Given this list of marker genes Gdnf (NCBI Gene Id 14573), Hes3, Plxna3, Sema3f (NCBI Gene Id 20350), Nav2, Phox2a, Adarb1, Ackr3, Nrp1, Nrp2, Sema3a, Hoxb1, Ascl1, Hoxa1, Tbx1, Plxna4, Egr2, Six1, Tfap2a, Hes1, Phox2b, Hoxb2, here is a description of the gene set: The process whose specific outcome is the progression of the parasympathetic nervous system over time, from its formation to the mature structure. The parasympathetic nervous system is one of the two divisions of the vertebrate autonomic nervous system. Parasympathetic nerves emerge cranially as pre ganglionic fibers from oculomotor, facial, glossopharyngeal and vagus and from the sacral region of the spinal cord. Most neurons are cholinergic and responses are mediated by muscarinic receptors. The parasympathetic system innervates, for example: salivary glands, thoracic and abdominal viscera, bladder and genitalia. species: Mus musculus Mouse Gene Set: GOBP_PARASYMPATHETIC_NERVOUS_SYSTEM_DEVELOPMENT